The following is a description of a gene set: studied in species Homo sapiens Human Gene Set: GSE10240_CTRL_VS_IL17_AND_IL22_STIM_PRIMARY_BRONCHIAL_EPITHELIAL_CELLS_DN Genes down-regulated in primary bronchial epithelial cells: control versus stimulated with IL17A and IL22. from publication Aujla SJ, Chan YR, Zheng M, Fei M, Askew DJ, Pociask DA, Reinhart TA, McAllister F, Edeal J, Gaus K, Husain S, Kreindler JL, Dubin PJ, Pilewski JM, Myerburg MM, Mason CA, Iwakura Y, Kolls JK (PMID 18264110) Primary HBE cells were stimulated with IL-22 and IL-17, and gene expression was studied using an Affymetrix platform microarray, in order to investigate which genes may be upregulated or downregulated in response to these cytokines. Of particular interest was the host defense genes such as antimicrobial peptides, which have been shown to be upregulated by IL-22 and IL-17 in skin keratinocytes., and this is the list of marker genes: EXO1, CCDC14, TIMELESS, LUC7L, SCIN, ARHGAP21, JDP2, ZNF428, TMEM8B, URI1, SLC22A3 (solute carrier family 22 member 3), EEF2K, LPAR2, TTC13, CD47, CUL7, CENPM, AMPD2, PKIG, CUX1, TRIP13, TSC22D1, MBTD1, CDCA2, CBFA2T3, ZNF679, DHFR (NCBI Gene Id 203373), LMNB1, LPIN2, CSAD, DDX39B, RAD51B, MYB, ST6GALNAC6, MCM10, LZTS2, RXRB, ADGRB1, ATP2A2, CBX2, ARID1B, TET1, POLD1, CACNB1, PDPN, TIA1, IVNS1ABP, BASP1, CIPC, AMTN, RBP2, BCL11A, PLSCR3 (phospholipid scramblase 3), FHIT, CHCHD10, RHOB, WDFY4, CCND1, EXOC4, G6PC3, TP53BP1, ELK3, MBL2, HOXA9, MYH1, ESPL1, HDAC9, CKAP4 (NCBI Gene Id 732190), SMARCC1, ELP2, WDR64, ADM2, KIF17, TBC1D24, TLNRD1, KCTD12 (NCBI Gene Id 80710), SLIT3, DNAJC6, CDK19, PARP1, MXRA7, CTNND2, SYK, HOXB13, PTGDR2, IGLL1, TMEM176A, BTNL9, COBLL1, NAT8L, MFAP3, CHEK1, PPM1F, CENPN, CYB561A3 (NCBI Gene Id 378885), CLCN3, BAHCC1, FOXRED2, TGM5, MAOA, PPARD, SCN8A, RUNX2, CDS1, CSF2RB, BRD3, CDCA5, TRIM28, PCP4, MACROH2A1, SPAG5, GAB1, CHST11, MEF2C, NOTCH1, WDR31, C1orf116 (chromosome 1 open reading frame 116), HNRNPU, CKAP2L, UPF2, TTBK2, ZMYM3, HCN1, TUBB6, RHOBTB3, KIF22, PRKCE, CBX5, CDCA8, SKA2, KIF23, CCDC138, ABL2, S100A1, CTSE, ZNF629, KHDRBS3, EPB41L3 (NCBI Gene Id 8730, erythrocyte membrane protein band 4.1 like 3), CIRBP, MEX3A, COLGALT1, EHMT1, BAIAP2L1, UHRF1, KRT18, ABCB10, CLCN5, STK35, ZNF296, SCAP, PLEKHA7, DENND5A, HADH, GPR137, RBP7, MAP3K20, RFC1, PALM, HK2, COL16A1, MARCKSL1, ATP13A2, TMEM176B, CDCA3, TFDP2, ADGRL4, SRL, CDKN1A, FCHO1 (FCH and mu domain containing endocytic adaptor 1), H2AZ1, SASH1, ZNF397, ZNF518B, GREB1L, NCAPH, SLC23A1, PSD3, IFITM3, ZC3H12C, GPSM1, RNF157, FIRRM, RRM2, ARHGEF10, DHX33, CX3CR1, SEPHS1, ANKS1A, DNASE2, HBEGF, CAMKV (CaM kinase like vesicle associated), BCAT1, LRRK1, PPFIBP2, CHST15, KRT16, CNTROB, SLC38A2, DOCK7, GTF3C4